The following is a description of a gene set: Menin is encoded by the tumor suppressor gene MEN1 that is mutated in patients with an inherited tumor syndrome, multiple endocrine neoplasia type 1 (MEN1). Although menin is a nuclear protein and directly binds to DNA through its nuclear localization signals (NLSs), the precise role for each of the NLSs in nuclear translocation and gene expression remains to be elucidated. Here, we show that point mutations in three individual NLSs, NLS1, NLS2, and a novel accessory NLS, NLSa, do not block nuclear translocation, but compromise the ability of menin to repress expression of the endogenous insulin-like growth factor binding protein-2 (IGFBP-2) gene. This repression is not released by an inhibitor of histone deacetylases. Although subtle mutations in menin NLSs do not affect menin association with chromatin, they abolish menin binding to the IGFBP-2 promoter in vivo. Furthermore, each of the NLSs is also crucial for menin-mediated induction of caspase 8 expression. Together, these results suggest that menin may act as a scaffold protein in coordinating activation and repression of gene transcription and that its NLSs play a more important role in controlling gene transcription than merely targeting menin into the nucleus. species: Mus musculus from publication La P, Desmond A, Hou Z, Silva AC, Schnepp RW, Hua X (PMID 16449969) Genes up-regulated in cells expressing MEN1. Mouse Gene Set: LA_MEN1_TARGETS, and this is the list of marker genes: Casp8, Bex1, Nupr1, Snx10, Cavin3, Anp32a, Sorbs1, Sall3, Frrs1, Hsd17b11 (NCBI Gene Id 114664), Rgs16, Fgf13, Cnn1, Adam19, Crabp1, Hoxb8, Igfbp5, Bcl6b, Tspan7 (NCBI Gene Id 97622), Itga5, Acot1, F3, Ddr2, Pter, Azi2